The following is a description of a gene set: Mouse Gene Set: MIR_488_5P Genes predicted to be targets of miRBase v22 microRNA mmu_miR_488_5p in miRDB v6.0 with MirTarget v4 prediction scores > 80 (high confidence targets). studied in species Mus musculus from publication Chen Y, Wang X (PMID 31504780), and this is the list of marker genes: Ints6, Kcna6, Isoc1, Adnp, Klhl7, Tasor, Capn2, Tfap2a (NCBI Gene Id 21418), Egfem1, Tanc1, Wdr33, Actr3, Lactb2, Oma1, Tmem263, Ang5, Zkscan3, Rab10, Cxadr, Virma, Kcnj15, Icam2, Hif1a (hypoxia inducible factor 1, alpha subunit), Tub, Vps35, Cadm3, Cog6, Slc2a1, Rnft1, Zfp784, Gm11780, Gimap6, Chmp7, Meioc, Dclk2, Megf10 (NCBI Gene Id 70417), Kcnn3, Rcan2, Mier1, Colec10, Nav1, 1600012H06Rik, Leprot, Sp100 (NCBI Gene Id 20684), Cdk13, Atp1a1, Ncoa1, AW209491, Otub2, Gm12888, Tsfm, Crem, Golph3, Synpo, Otc, Topors, Prrg1, Tcea1, Ddx46, Pfn2, Ints6l, Vgll3, Lfng (LFNG O-fucosylpeptide 3-beta-N-acetylglucosaminyltransferase), Fign, Cyp2j11, Gulp1, Agpat1